The following is a description of a gene set: from publication Chen Y, Wang X (PMID 31504780) Mouse Gene Set: MIR_6380 studied in species Mus musculus Genes predicted to be targets of miRBase v22 microRNA mmu_miR_6380 in miRDB v6.0 with MirTarget v4 prediction scores > 80 (high confidence targets)., and this is the list of marker genes: Serpina7, Ces2c, Senp5, Phc3, Zfyve21, Hsf5, Lrrtm4, Rbfox1, Zbtb18 (NCBI Gene Id 30928), Lonrf3, Mrpl41, Asap1 (NCBI Gene Id 13196), Foxn2, Plekhd1, Alx4, Ccnc, Usp46, Suclg1, Tafa2, Zfp493, Col5a2, Mpeg1, Adora2b, Smyd4, Lefty2, Ywhaq, Ikzf4, Slc2a8, Slc29a3, 2410002F23Rik, Podn, Arf6, Slc4a7, Ppp4r3b, Kcnd2, Hdac9, Camkk2, Mtmr6, Tfap4, Vcan, Ifi213, Ces2b, Ralgds, Lman1, Pold3, Osmr, Irf2, Me1, Tcf24, 4930579F01Rik, Phf8, Slc25a30, Prdm4, Carmil1, Epha1, Nr2f2, Unc5a, Cyp2j13, Nfia, Taf5, Lrrcc1, Tmem255a, Catsperb, Lpcat2, Far2, Rictor, Ikzf2, Foxg1